Given this list of marker genes CREB1, SLC22A2, KCNJ10, SLC1A2, CAMKK1, CHRNA2, HRAS, TUBB4B, ADCY6, GABRB1, TUBAL3, ADCY3 (adenylate cyclase 3), CHRNB3, RPS6KA1, NRG1 (NCBI Gene Id 653104), PRKAR1A, PLCB3, SLC17A7, TUBA3D, SLC38A2, GNGT2, CACNG2, PPM1F, CAMK2B, GABRB3, GRIK3, CACNG8, PPFIA1, GNB2, GRIP2, SYN3, AP2A1, NSF, LIN7C, ABAT, PRKACB, KIF17, TSPAN7 (tetraspanin 7), CHRNA7, GNAT3, PRKAR1B, ACHE, GABBR1, GABRG2, LIN7A, PRKAB1, GLS2, NRGN, ARHGEF9, TUBB2A, AP2A2, ADCY8, PRKCA, GABRQ, GNG8 (G protein subunit gamma 8), CHRND, GRIN3B, GLS, LRTOMT, CACNG3, CAMK2D, PPFIA3, GAD1, PRKACA, PRKACG, PRKCB, EPB41L1, PDPK1, MAOA, ALDH5A1, RPS6KA3, PPM1E, BCHE, GNAL, CACNB1, GRIK5, GRIK4, PRKAG3, GRIK1, PRKAG2, GABBR2, KCNJ9, RAB3A, PRKAR2B, SLC5A7, CAMK2G, GNGT1, TUBB4A, CHRNA5, LRRC7, SLC1A6, RIMS1, HSPA8, CAMKK2, ADCY9, NAAA, STXBP1, HTR3A, PLCB2 (NCBI Gene Id 5330), TUBB1, PRKCG, CHRNA9, TUBA1B, GNG10, GABRA5, SLC38A1, GNG12, TUBB8, PRKX, CHRNA4, CACNA1B, ADCY7, GABRR1, HTR3E, ACTN2, ADCY2 (adenylate cyclase 2), SRC, GRIN1, CAMK2A, LIN7B, GLRB, CAMK1, TUBA4B, PRKAR2A, TUBB6, GRIP1, SLC1A7, SLC18A2, CHRNG, NCALD, KCNJ5, TUBA1C, DLG1, CHAT, GNG3, TUBA1A, GLRA2, PRKAG1, PPFIA2, PRKAB2, GAD2, KCNJ3, PPFIA4, GABRA4, GABRA1, DLG2, HTR3D, MDM2, ERBB4, PRKAA2, SNAP25, SYT1, GABRR2, GNB3, NBEA, DLG3, GRIK2, GNG4, GABRG3 (gamma-aminobutyric acid type A receptor subunit gamma3), CACNG4, LRRC51, SLC6A11, CAMK4, GLRA1, MYO6, GABRR3, GRIA3, GABRA2, TUBA3C, ADCY4, GRIA1, ALDH2, KCNJ15, VAMP2, RPS6KA2 (NCBI Gene Id 6196), GNG13, NRAS, TUBB8B, RASGRF1, RPS6KA6 (NCBI Gene Id 27330), GRIN3A, SLC1A3, CHRNA3, GRIA2, RASGRF2, SLC6A12, GABRB2, STX1A, TUBA3E, APBA1, ARHGEF7 (NCBI Gene Id 8874), GNAI3, KPNA2, GNG7, SLC18A3, SLC1A1, AP2B1, CPLX1, PRKAA1, TUBB3, NPTN, CHRNB4, DNAJC5, GNG5, ADCY1, UNC13B, RAC1, MAPT, KRAS, CACNB3, MAPK3, SLC6A3, COMT (catechol-O-methyltransferase), GIT1, GNAI2 (G protein subunit alpha i2), CACNB2, TUBB2B, SLC6A1, SLC32A1, CALM1, TSPOAP1, CHRNA1, CASK, SLC6A4, CHRNB2, GNB4, GNG11, MAPK1, GABRA3, AP2M1, GRIN2B, GNB1, AP2S1, GRIN2A, KCNJ2 (NCBI Gene Id 3759), PICK1, NEFL, GNG2, TUBA8, CACNA1E, KCNJ4, CHRNA6, AKAP5 (A-kinase anchoring protein 5), SYN2, GRIN2C, CACNA1A, GABRA6, GLRA3, DLG4, HTR3B, GRIN2D, CACNA2D3 (calcium voltage-gated channel auxiliary subunit alpha2delta 3), KCNJ6, SLC6A13, GNB5, CHRNE (cholinergic receptor nicotinic epsilon subunit), PLCB1, ARL6IP5, GNAI1, GLUL, HTR3C, KCNJ16, KCNJ12, GRIA4, TUBA4A, CACNB4, ADCY5, CACNA2D2, SLC22A1, SYN1, here is a description of the gene set: studied in species Homo sapiens Human Gene Set: REACTOME_TRANSMISSION_ACROSS_CHEMICAL_SYNAPSES Transmission across Chemical Synapses